Given this list of marker genes Ppargc1b (peroxisome proliferative activated receptor, gamma, coactivator 1 beta), Nckap1l, Clec1b, Ccr1l1, Ifi208, Med1, Srp54b, Ccl21b (NCBI Gene Id 20298), Hif1a, Kitl, Nedd9, Psen2, Fshb, Jak2 (Janus kinase 2), Lrrk1 (NCBI Gene Id 434196), Sp1, Trim58, Il5, Hoxa9, Dmtn, Pip4k2a, Isg15, Lilrb4a, Cbfa2t3, Traf6, Mfhas1, Cd109, Gab3, Ror2, Ltf, Kat7, Adar, Bmp4, Rbp1, Slc1a5, Tfe3, Rara, Fas, Sfxn1, Tpm4, Tcta, Ypel4, Src, Tyrobp, Il17c, Vps13a, Cd81, Chuk, Rabgap1l, Gpr55, Scin, Zfp385a, Il34, Gba1, Paf1, Tmem64, Tlr2, Nr3c1, Stat1, Prkdc, Mturn, Mndal, Gata2, Itgam, Hhex, Nf1, Stat5b, Skic8, Clec2g, Rb1, Exoc6, Creb1, Hcls1, Sox6, Bmyc, Lrrc17, Gp1ba, Fbxw7, Prkx, Ctr9 (NCBI Gene Id 22083), Csf3, Brd1, Pla2g10, Psen1 (NCBI Gene Id 19164), Il31ra, Tifab, Hdac6, Il23a, Pml, Cdk6, Apc (APC, WNT signaling pathway regulator), Mir146, Itgb6, Ctnnbip1, Farp2, Epas1, Adipoq, Ccdc39, Hoxa7, Myc, Rarg, Hbb-bs (NCBI Gene Id 15129), Fshr, Pir, Tesc, Ptpn11, Notch2, Abcb10, Senp1, Gpc3, Plcb1, Kdm1a (lysine (K)-specific demethylase 1A), Trim10, Junb, Alas2, Itpkb, Abi1, Csf3r, Lyar, Tgfb1, Gpr137b, Smad5, Pira1, Rassf2, Mpl, Mir122, Ercc2, Glo1, Itgb8, Rbfox2, Csf1, Twist2, Pou4f1, Gata1, Zbtb46, Tspo2, Gfi1b, Ifi214, Ndp, Ifi206, Cdk5rap3, Apcs, Pilrb1, Ets1, Lef1, Cbfb, Gpr171, Il12b, Actn1, Il1rl1, Hax1, Nfe2l1, Myd88, Uba5, Hmgb3, Prdx3, Ep300, Glul, Mef2c, Gimap3, Kit, Evi2, Zbtb7a, Smarca4, Hspa9, G6pdx, Nkap, Eif2ak1, Ptk2b, Clpb, Srp54a, Epha2, Slc4a2, Naglu, Lipa, Fosl2, Fadd, Stap1 (signal transducing adaptor family member 1), Ifi207 (interferon activated gene 207), Ostm1, Sp3, Rhag, Hoxb7, Ifi203-ps, Ncapg2, Ap3b1, Ighe, Mir223, Clec5a, Add1, Qki, Ptprj, Tescl, Fasn, Rbpj, Tmod3, Fli1, Ccl5, Vps33b, Fam3c, Tmem14c, Lox, Cited2, B2m, Erfe, Inhba, Efna2, Fech, Tnfsf9, Mir125a, Ncor1, Inpp5d, Tnf, Tnfsf11, Pla2g3, Heph, Lbr, Rps14, Eif6, F2rl1, C1qc, Pias3, Rbm15, Cnot4, Pabpc4, Gm15915, P4htm, Mafb, Tgfbr2, Vegfa, Hoxa5, Cd4, Batf, Vps33a, Vps54, Cldn18, Dhrs7b, Ndfip1, Acvr2a, Slc11a2, Dcstamp, Ift80, Setd1a, Meis2, Nfatc1, Prmt1, Trib1, Siglec15, Lyn, Foxo3, Cdin1, Gnas, Spib, Irf4, Ankrd54 (NCBI Gene Id 27619), Anxa2, Thoc5, Kat6a, Stat5a, Tlr4, Lmo2, Gmpr2, Kcnq1, Zfpm1, Ubash3b, Plscr1, Oscar, Bmp2, Dlk1, Csf2, Acin1, Rab7b, Myh9, Wasf2, Tubb1, Mitf, Large1, Stat3, Mir451b, Snx10, Slc4a1, Hba-a2, Arid4a, Jagn1, Zfp36l1, Gimap5, Il17a, Camk4, Cebpb, Sh3pxd2a, Sirt1 (NCBI Gene Id 93759), Blvrb, Ucp2, Ccn4, Casp8, Gsk3b, Irf8, L3mbtl3, Hspa1b, Pafah1b1 (NCBI Gene Id 94322), Rptor, Jag1, Flvcr1, Tnfrsf11a, Il20, Ninj1, App, Rcor1, Tfrc, Ank1, Cartpt, Ldb1, Fstl3, Ltbr, Bbln, Fcer1g, Sbno2, Ifi203, Tspan2, Iapp (islet amyloid polypeptide), Nemp1, Lilrb4b, Pou4f2, Lif, Rps6, Prdm16, Ptpn6, Hmga1, Cebpe, Ptpn2, Sfrp1, Fam20c, Bap1, Pirb, Ppp3ca, Tgfbr3, Ncoa6, Fos, Ifnb1, Mpig6b (NCBI Gene Id 106722), Hmox1 (heme oxygenase 1), Cul4a, G6pd2, Chmp5, Inpp4b, Mfsd8, Cebpa, Myb, Rhd, Rac1, Fes, Srp54c, Cdkn2b, Nkx2-3, Ifng, Nrros, Clec2d (C-type lectin domain family 2, member d), Dll1, Ptbp3, Thpo, Ikzf1, Ireb2, Hscb, Calcr, Ceacam1, Runx1, Kat8, Eeig1, Atp6ap1, Bpgm, Pparg, Bcl6, L3mbtl1, Flna, Asxl2, Ripk1, Kmt2e, Hnrnpu, Dnase2a, Esrra, Gabpa, Nfkbia, Cib1, Mfap2, Gab2 (growth factor receptor bound protein 2-associated protein 2), Prtn3, Hmgb1, Ccl3, Adam8, Gp1bb, Cflar, Bloodlinc, Epsti1, Car2, Pde1b, Wdr1, Epb42, Maf, Hmgb2, Evi2b, Tmem178, Jmjd6, Il15, Arid3c, Prxl2a, Pf4, Slc48a1 (solute carrier family 48 (heme transporter), member 1), Fbn1, Id2, Klf13, Igsf23, Nme1, Ifi209, Maea, Thra, Csf1r, Alas1, Sh2b3, Tirap, Ifi213, Mtor, Tcirg1, Nme2, Slc25a38, Gata3, Klf1 (NCBI Gene Id 17953), Srf, Cebpg, Socs1, Rnf41, Il4, Tnfrsf11b, Tcea1, Clec2i, Tet2, Cd101, Batf2, Il25, Zfp36, Klf10, Pithd1, Fam210b, Etv2, Fgfr3, Rac2, Mir451a, Slc25a5, Tnfaip6, Gpr137, Cd300lf, Tjp2, Cdc73, Acvr1b, Nfix, Dyrk3, Gpr183, Hba-x, Ehbp1l1, Gp5, Pknox1, Cdkn1c, Mir144, Itgb3, Pira12, Faxdc2, Dab2, Foxp1, Tob2, Tal1, Diaph3, Gp9, Ctnnb1, Ufl1, Il3, Atp5if1, Smap1, Il33, Casp3, Trem2, Ccr7, Selenow, Ccl19, Cd74, Slc25a40, Rps19, Pik3r1, Prkca, Mb, Enpp1, Ankle1 (ankyrin repeat and LEM domain containing 1), Ubd, Adgrf4 (adhesion G protein-coupled receptor F4), Racgap1, Ocstamp, Meis1, Epo, Slc9b2, Ahsp, Trf, Spi1, Ccr1, Relb, Tcf3, Hoxb8, Nbeal2, Mapk14, Gpr68, Adgrf5, Ccl9, Jun, Batf3, Leo1, Heatr3, Hsf1, Klf2, Hba-a1, here is a description of the gene set: species: Mus musculus Mouse Gene Set: GOBP_MYELOID_CELL_DIFFERENTIATION The process in which a relatively unspecialized myeloid precursor cell acquires the specialized features of any cell of the myeloid leukocyte, megakaryocyte, thrombocyte, or erythrocyte lineages.